The following is a description of a gene set: studied in species Homo sapiens Any process that activates or increases the frequency, rate, or extent of interleukin-13 production. Human Gene Set: GOBP_POSITIVE_REGULATION_OF_INTERLEUKIN_13_PRODUCTION, and this is the list of marker genes: IL17RB, PRKCZ, TNFSF4, IL17RA, RARA, LGALS9, IL33, HLA-E, GATA3, IL4, IRF4, IL1RAP, TSLP (NCBI Gene Id 85480), SPHK2, IL18